The following is a description of a gene set: studied in species Mus musculus The process in which a relatively unspecialized cell acquires the specialized features of a retinal rod cell. Mouse Gene Set: GOBP_RETINAL_ROD_CELL_DIFFERENTIATION, and this is the list of marker genes: Samd7, Gnat2, Bhlhe23, Nrl, Rpgrip1, Alms1, Cntf, Ntrk2, Trpm1, Sox9, Samd11, Stat3, Rp1, Sox8, Gnat1, Bbs4, Casz1, Rorb, Miat, Naglu, Ptn, Ndp, Ahi1, Cfh, Rpgrip1l, Bbs10